Given this list of marker genes Bmal1, Tfdp1, Zbtb17, Ccnc (cyclin C), Pias3 (NCBI Gene Id 54605), H3c8, Gcm2, C1d, Cenpb, Bmi1, Nfix, Stat1, Cenpc1 (NCBI Gene Id 231379), Top2a, Rab2a, Rab7, Stat5b, Cdkn2d, Rab1a, Ankfy1, Trim27, Cenpa, Polg2, Kif4, Hnrnpdl, Mcm7, Pold1, Smarce1, Mcm3, Gata1, Terf2, Ankrd49, Hmgb1, Ank1, Gm4739, Clock (NCBI Gene Id 620729), Nfyc, Uhrf1 (NCBI Gene Id 18140), Ezh2, Blm, Etaa1, Smad6, Zfp35, Supt4a, Mybl2, Ybx3, Atf1, Per3, Mcm4, Elf4, Fen1, Rbl1, Id1, Brca1, Pola1, Exo1, Dnmt1, Mid1, Hmgn2, Rxra, Dhx9, Pias2, Max, Sp3, Mbd4, Pax4, Hsf1, Cbx3, Mafg, Pla2g6, Mcm2, Nfyb, Fosl2 (NCBI Gene Id 14284), E2f1, Polr2j, Mcm5, Pou2f1 (POU domain, class 2, transcription factor 1), Pbx2, Aurkb, Foxh1, Pole2, Ctcf, Pou2f3, here is a description of the gene set: Selected gradually up-regulated genes in the TLX1 Tet On iEBHX15-4 cells (pro-erythroblasts). species: Mus musculus from publication Riz I, Akimov SS, Eaker SS, Baxter KK, Lee HJ, Mariño-Ramírez L, Landsman D, Hawley TS, Hawley RG (PMID 17213805) Aberrant expression of the human homeobox-containing proto-oncogene TLX1/HOX11 inhibits hematopoietic differentiation programs in a number of murine model systems. Here, we report the establishment of a murine erythroid progenitor cell line, iEBHX1S-4, developmentally arrested by regulatable TLX1 expression. Extinction of TLX1 expression released the iEBHX1S-4 differentiation block, allowing erythropoietin-dependent acquisition of erythroid markers and hemoglobin synthesis. Coordinated activation of erythroid transcriptional networks integrated by the acetyltransferase co-activator CREB-binding protein (CBP) was suggested by bioinformatic analysis of the upstream regulatory regions of several conditionally induced iEBHX1S-4 gene sets. In accord with this notion, CBP-associated acetylation of GATA-1, an essential regulator of erythroid differentiation, increased concomitantly with TLX1 downregulation. Coimmunoprecipitation experiments and glutathione-S-transferase pull-down assays revealed that TLX1 directly binds to CBP, and confocal laser microscopy demonstrated that the two proteins partially colocalize at intranuclear sites in iEBHX1S-4 cells. Notably, the distribution of CBP in conditionally blocked iEBHX1S-4 cells partially overlapped with chromatin marked by a repressive histone methylation pattern, and downregulation of TLX1 coincided with exit of CBP from these heterochromatic regions. Thus, we propose that TLX1-mediated differentiation arrest may be achieved in part through a mechanism that involves redirection of CBP and/or its sequestration in repressive chromatin domains. Mouse Gene Set: RIZ_ERYTHROID_DIFFERENTIATION